The following is a description of a gene set: The process in which the branching structure of the salivary gland is generated and organized. Human Gene Set: GOBP_BRANCHING_INVOLVED_IN_SALIVARY_GLAND_MORPHOGENESIS species: Homo sapiens, and this is the list of marker genes: BMP7, FGFR1, FGF8, PDGFA, LAMA5, PLXNA1, TGM2 (NCBI Gene Id 7052), FGFR2, FGF7, PLXND1, HGF, ESRP2, TNF (NCBI Gene Id 7124), SNAI2, NRP1, LAMA1, FGF10, BTBD7, NTN4, DAG1, SHH, SEMA3C